Given this list of marker genes GRID2, GRIK3, GRIN3B, GRIA1, GRIK4, GRIN3A, GRIK2, GRIN2B, GRIA4, GRIN2D, GRIN1 (glutamate ionotropic receptor NMDA type subunit 1), GRIK5, GRIN2C, GRIK1 (glutamate ionotropic receptor kainate type subunit 1), GRIA3, GRIN2A, GRID1, GRIA2, here is a description of the gene set: species: Homo sapiens Human Gene Set: GOMF_GLUTAMATE_GATED_RECEPTOR_ACTIVITY Catalysis of the transmembrane transfer of an ion by a channel that opens when glutamate has been bound by the channel complex or one of its constituent parts.